The following is a description of a gene set: part of: Disorders of transmembrane transporters The solute-carrier gene (SLC) superfamily encodes membrane-bound transporters comprising 55 gene families with at least 362 putatively functional protein-coding genes. The gene products include passive transporters, symporters and antiporters and are located in all cellular and organelle membranes. Curated here is a list of SLCs, where mutations within them can result in disease. Reactome Pathway: SLC transporter disorders species: Homo sapiens, and this is the list of marker genes: HK1, AVPR1B, SLCO1B1, SLC9A9, SLC2A10, SLC34A1, SLC17A8, SLC5A5, NUP133, NUP205, SLC12A6 (NCBI Gene Id 9990), SLC5A7, SLC6A20, NUP62, AAAS, SLC3A1, SLC12A3, NDC1, RHAG, SLC7A9, SLC11A2, AVPR1A, BSG, POM121C, GCK (NCBI Gene Id 2645), NUP98, SLC2A1, SLC26A3, NUP35, SLC26A4, NUP85, SLC67A1, SLC22A5, RANBP2, SLC39A4, SLC16A1, NUP88, NUP210, SLC35C1, SLC5A2, SLC24A5, NUP37, SLC36A2, SLC5A1, CP, SLC6A19, SLC4A1, SLC29A3, SLC35A1, SLC27A4, SLC20A2, SEH1L, NUP188, NUP43, SLC24A4, SLC7A7, SLC22A12, SLC2A2, SLCO2A1, GCKR (NCBI Gene Id 2646), SLC34A3, SLC24A1, AVP, NUP50, SLC1A3, SLC6A3, RAE1, SLC9A6, HEPH, SLC35A3, SLC35A2, SLC34A2, SLC33A1, SLC2A9, SLC4A4, NUP107, POM121, AVPR2, SLC17A5, SLC26A2, SEC13, SLC6A5, SLCO1B3, SLC1A1, NUP153, NUP155 (NCBI Gene Id 9631), NUP214, SLC6A14, NUP93, NUP160, SLC12A1, SLC40A1, TPR, NUP42, NUP54, NUP58, SLC3A2, SLC6A2